The following is a description of a gene set: studied in species Homo sapiens Human Gene Set: HP_PINEAL_CYST Pineal cyst A glial uniloculated or multiloculated fluid-filled sac that either reside within or completely replace the pineal gland., and this is the list of marker genes: NONO, PSMD12, ADNP, KRAS, WDR26, PNPLA2, GALNT2, RNU4-2, KANSL1, BPTF